The following is a description of a gene set: Human Gene Set: GOBP_WOUND_HEALING studied in species Homo sapiens The series of events that restore integrity to a damaged tissue, following an injury., and this is the list of marker genes: ALOX15, PRKG1, SYK, INS, USF1, KANK1, MIR29A, CPB2, DCBLD2, EVPL, ITGB5, ITPR3, MTOR, DGKD, PLAUR, ITPK1, MIR451A, RHOA, DRD5, DGKK, XBP1, F10, EPB41L4B, GP5, SERPIND1, STXBP3, TMX1, OCLN, FOXC2, TGFB1, NPR2, ARHGAP24, IL1A, JAK2, KDR, FBLN1, FAP, HTN1, NACA, MERTK, WNT3A, VTN, PRKCQ, CD109, CLASP2, AQP1, EPHB2, PIK3CG, HGFAC, PRSS56, GATA1, PTK2, SERPINE2 (serpin family E member 2), P2RY12, F2, BLOC1S3, LCP1, PIK3CB, PDGFB, PLCG2, WAS, COL5A1, PIK3CA, TLN1, ANO6, POU2F3, PTK7, RAB27A, PRKCA (protein kinase C alpha), CLEC7A, WNT7A, DGKQ, JAML, ANGPTL7, TMEM97, MFSD2B, CHMP1B, SMPD1, NLRP6 (NLR family pyrin domain containing 6), SELP, CAV1, MYOF, HNF4A, SRSF6, GGCX, GNA13, KRT6A, CRK, NRG1, S100A10, AK3, SLC6A4, HMGB1, PHLDB2, BLOC1S6, MMP12, ADAM17, HTN3, FGF2, NF1, IL6ST, FGA, JMJD1C, PRRG4, SH2B3, F9, CD59, SYT11, ACTN1, EMILIN2, COMP, DGKB (NCBI Gene Id 1607), SERPINE1, PPARD, C1QTNF1 (NCBI Gene Id 81852), DDR2, HPS6, CD151, PROZ, CD44, SERPINF2, STXBP1, CHMP5, HMOX1, CSRP1, C4BPB, PDPN, GNAS, MIA3, MIR34A, TEC, AJUBA, FGB, DGKA (NCBI Gene Id 1606), GNA12, CDKN1A, PLA2G4A, TGFB2, CLDN3, TNFRSF12A, SAA1, CLIC1, TAFA5, EMILIN1, CD34, GP1BA, DGKI, F7, PDGFRA, CADM4, TSKU, SLC4A1, TGFBR1, ENG, CARMIL2, SCRIB, MYL9, ENTPD1, WNT5A, FGF1, SERPINB2, NFE2L2, VANGL2, THBD, PABPC4, SPRR3, THBS1, TLR4, ITGB6, FIGNL2, ARHGAP35, DST, C6orf89, HRG, FERMT1, AP3B1, IGF1, VIL1, VKORC1 (vitamin K epoxide reductase complex subunit 1), CAV3, ANGPT1, ALOX5, CX3CL1, AHNAK, ITGA2, PLAT, KLKB1, ANGPTL6, SFTA3, HTR2A, WFDC1, PLAU, NOG, ADGRG1, ADRA2C, TYRO3, MAPK14, PPARA, PRRG1, GP6, TREML1 (triggering receptor expressed on myeloid cells like 1), ODAM, CHMP7, SCUBE1, SCARB1, NOS3 (NCBI Gene Id 4846), FOXA2, METAP1 (NCBI Gene Id 23173), PRKCD, FUNDC2, VPS33B, CHMP2B, TIMP1, PDCD10, ERBB2, KRT1, COL3A1, TPM1, VAV2, CYP4F11, MRTFA, AJAP1, MMRN1, TOR1A, MYL12A, CHMP1A, EPPK1, RAB3A, HRAS, DUOX1, ENTPD2, TUBB1, HBB, ANXA2, MYOZ1, FKBP10, MYH9, SRF, PRRG3, DDR1, HPS4, CNN2, F3, ANGPTL4, SYT7, GPX1, EXT1, GRHL3, PROS1, FLNA, ITGA5, CTSG, ANGPT2, ADRA2A, ACTG1 (actin gamma 1), DGKZ, DGKE, EREG, ANGPTL1, GNAQ, TSPAN8, DMTN, BLOC1S4, ANXA5, ELK3, MPIG6B, PPIA, MYLK, F8, LCK (LCK proto-oncogene, Src family tyrosine kinase), PRKCE, VPS4B, ILK, ITGB3, MCAM, SERPINA1, ANXA1, TRIM72, HPS5, SLC12A2, ARL8B, F12, PTPRJ, ACVRL1, F2R, FCER1G, CHMP2A, P2RY1, PF4, CHMP4C, TSPAN32, MIR15B, WNT4, PDGFA, ENPP4, NDNF, ADAMTS18, VEGFB (NCBI Gene Id 7423), FGFR1OP2, APOE, SLC11A1, PLET1, FERMT3, CD9, ANXA8, VAV3, MIR200B, TNF, PROC, SDC4, SRC, LMAN1, GPR4, FUT10, FN1, PEAR1, ANGPTL2, MIR221, RREB1, F2RL1, MACF1, F11R, PLEK, AGER, MSX2, TFPI2, VAV1, TNFAIP3 (TNF alpha induced protein 3), VEGFA, FGG, CASP7, PAFAH2, DSP, CD40, ADAMTS13, ADTRP, SVEP1, PROCR (protein C receptor), CLDN4, VWF, HIF1A, HSPB1, F13A1, ADIPOR2, NOTCH2, CHMP4A, SMAD3, ITGB1, SERPINC1, TFPI, VPS4A, DTNBP1, GP9, KNG1, TSPAN9, PTPN6, INSL3 (NCBI Gene Id 6020), CELA2A, F13B, CCN4, FERMT2, SYTL4, ANGPT4, FGL1, F5, REG3A, PRDX2, F11, ARHGEF19 (NCBI Gene Id 128272), RAF1, CHMP6, REG3G, B4GALT1, DGKG, LYN (LYN proto-oncogene, Src family tyrosine kinase), SHH (sonic hedgehog signaling molecule), LRG1, CHMP4B, PAK1, ARFGEF1, PLSCR1, CLASP1, DUOX2, MYH10, PTEN (phosphatase and tensin homolog), RAP2B, CLDN1, DAG1, LACRT, ALOX12, CHMP4BP1, CASK, FGF10, SERPINA10, HBEGF, RASA3, FIBP, FZD7 (NCBI Gene Id 8324), P2RX1, SLC7A11 (NCBI Gene Id 23657), UBASH3B, PRRG2, PECAM1, MIR17, CD40LG, PLG, PPL, PDIA2, GATA4, ACTB, MIR1298, ST3GAL4, FZD6, EDN1, PLEC, PDIA3, GAS6, PRCP, ADRA2B, F2RL3, SERPING1, CYP4F2, VCL, IL6R, DGKH, YAP1, AXL, IL6, CD36 (NCBI Gene Id 948), HPSE, PPP3CA, ERBB3, F2RL2, GATA2, C1GALT1C1, ADORA2A, APCS, APOH, TBXA2R, CHMP3, PPARG, RHOC, ITGAV, ANO5, SMOC2, GP1BB, CEACAM1, CORO1B, TMEFF2, LNPK